The following is a description of a gene set: Pathway Definition from KEGG: PRNP -> CAV -> FYN -> PI3K -> PRKCD -> NOX2 -> ERK -> CREB => EGR1 Human Gene Set: KEGG_MEDICUS_REFERENCE_PRNP_PI3K_NOX2_SIGNALING_PATHWAY studied in species Homo sapiens PRNP-PI3K-NOX2 signaling pathway. Pathway ID: N01204. Pathway type: Reference. Pathway class: nt06465 Prion disease., and this is the list of marker genes: PRKCD, PIK3CD, CREB3L3, FYN, MAPK3, CAV1, NCF2, CREB1, ATF4, RAC2, MAPK1, EGR1, CAV2, NCF4, CREB5, CYBB, ATF6B, PRNP, CREB3L4, PIK3CA, RAC1, CREB3, PIK3CB, ATF2, NCF1, CAV3, CYBA, CREB3L1, CREB3L2